The following is a description of a gene set: Transcriptional response of murine allogeneic T cells (B10.BR) after stimulation with different organ-derived (spleen, liver, peripheral and mesenteric lymph nodes) dendritic cells (C57BL/6) in vitro species: Homo sapiens Genes down-regulated in allogeneic T cells after stimulation with dendritic cells from: liver versus peripheral lymph nodes (pLN). from publication Kim TD, Terwey TH, Zakrzewski JL, Suh D, Kochman AA, Chen ME, King CG, Borsotti C, Grubin J, Smith OM, Heller G, Liu C, Murphy GF, Alpdogan O, van den Brink MR (PMID 18178870) Human Gene Set: GSE5503_LIVER_DC_VS_PLN_DC_ACTIVATED_ALLOGENIC_TCELL_DN, and this is the list of marker genes: DCTN4, HVCN1, BIRC6, CUL4B, ADAM9, MAPK7, QTRT2, PLK4, CYRIB, SMAP1, USP9X, ABCB10, MTMR4, FRS2, OPA1, CDK8, CHCHD1, MPP7, SERAC1, L3MBTL3, ARF6, PDIK1L, FUBP1, ENTPD7, C1orf74, GNL3, ASXL1, ATG2B, API5, MRPS9, ANKIB1, FKBP1A, NSUN3, GSPT2 (NCBI Gene Id 83029), ARL6IP6, PHLDB2, SUPV3L1, CYP39A1, LPAR2, BLTP3A, MAVS, ERO1B, PLEKHF2, RAPGEF6, ATP1B1, MTMR6, MED6, GAR1, EMB, CHSY1, SMARCD2, ATG4A, C9orf85, TASP1, MSL3, UBA5, SRF, TCN2, FUCA2, POLR1D, LIN9, EDEM3, SLC33A1 (NCBI Gene Id 9197), UBR3, ZNF708, THOC7, CACNA1D, IRAK4, CHST11, SGK3, UMAD1, FAM20B, DOLK, ZNF706, CASP8AP2, PHTF2 (putative homeodomain transcription factor 2), PPRC1, THAP12, PDCD10, GOLGA4, SAP130, ASCC3, UNC93B1 (NCBI Gene Id 81622), FAM91A1, BUB1, SCIN, PLEKHA1, FGL2, REEP5, FAM120A, CYLD, PARL, RAB5IF, ZNF330, KBTBD7, POGLUT2, ERCC6L, HSP90B1, TIRAP, ZBTB18, DHX33, DYNLT2B, TMEM170B, BLM, HSPA4, ZFYVE26, HELLS, PLG, MYO5A, WAPL, ANKLE2, WDR36, DSP, MAP3K1, HNRNPUL2, RSBN1, XDH, EIF3E, DNA2, NOL8, ZNF654, DNAJC24, WSB1, F10, SCPEP1, HIC2, MGAT2, TM6SF1, AKIRIN1, SLK, DTWD1, OTULINL (NCBI Gene Id 54491), POLR1A, DGAT1 (diacylglycerol O-acyltransferase 1), TMEM165, MCU, PNKD, TMEM50B, CBX4, NUBP2, EXOG, MFSD11, NCF1, STYX, YME1L1, MED17, AZIN1, TXNDC9, PAIP1, CAAP1, CLPTM1L, LRIF1, PTCD3, MED4, SYNJ2, ENDOD1, HINFP, ARHGAP26 (Rho GTPase activating protein 26), S1PR3, CNOT7, SUZ12, MMD, CSTF3, KBTBD8, SNRNP200, ZFP82, BLOC1S4, EPM2AIP1, ATAD1, CEP15, CEMIP2, CEP43, WDR20, TSHZ1, OAZ1, S100A11, AP1AR, TMEM69, CCDC93, ZNF639 (NCBI Gene Id 51193), RPL5 (ribosomal protein L5), EIF2B4 (NCBI Gene Id 8890), GORASP2, TUSC1 (NCBI Gene Id 389708), PNPLA7, CTNS, ZBTB34, CCT5, HDLBP, B4GALT6, ZDHHC5, ARHGAP19, KRR1, ELP1, DDI2, RBM27, NAE1 (NEDD8 activating enzyme E1 subunit 1), QRSL1, ZBTB44, POLR1F